Given this list of marker genes TSPAN18, FBN1 (NCBI Gene Id 7470), RARG, ADAMTS19, AIF1L, CBLN2, SPTY2D1, MYO1B, NAP1L1, NDUFC2-KCTD14, TSNAX, MEFV, GPLD1, SUMF1, SORBS3, TMEM263, TMEM229B, VAPB, UBTD2, EML5, STARD13 (NCBI Gene Id 90627), BAZ2B, ZNF839, ALK, GPX2, GIPC3, STK3, NRP1, FBXL7, HLTF, MYH10, TMEM33, TGFB2, KCTD14, IL20, RWDD2A, CLOCK, JDP2, TENT4B, MRFAP1, GRIPAP1, LDB2, GNG13, TASOR, MFSD6, KLF10, SYT14, KLHL42, MRPL19, RAB30, DCUN1D4, ARL4C, JAK2, C11orf24, ALX1, C2orf69, SPTBN1, PLXNC1, ITPRIPL2, NELL2, DNAJB1, ZNF710, ALOX12B, LIN7C, PTPRT, SUPT7L, BTBD10, RTP4, KCNA6, PPP2R2D, PTPRD, ARL6IP1, PIGZ, TLR7, IGF2BP2, MSANTD4, CRK, CNNM2, GRM7, IKBKE, AMMECR1L (AMMECR1 like), SLC25A36, MLF1, GNAS, TEAD1 (NCBI Gene Id 8), JADE3, CUL1, CUL4B, here is a description of the gene set: species: Homo sapiens Human Gene Set: MIR6843_3P from publication Chen Y, Wang X (PMID 31504780) Genes predicted to be targets of miRBase v22 microRNA hsa-miR-6843-3p in miRDB v6.0 with MirTarget v4 prediction scores > 80 (high confidence targets).